Given this list of marker genes CAMKK2, MMP3, LBP, TMEM132C, PALLD, C1QA, GALNT14, ZEB1, TSN, PTGER3, NTNG1, LGMN, PDE4DIP, CTSB, FEM1B, CNTN1 (contactin 1), EGLN3, NRROS, TRIL, IL1R1, KIF26B, ZFP36L1, SLC7A10, NR0B1, RAB7B, RHBDL3, TSPAN2, CCDC80, ASNS, ARMCX2, WFIKKN2, HIVEP2, SLCO2B1, AR, TTYH3, CCKAR, ATP2B1, FOXO6, FILIP1L, XIST, RALGDS, WASF1, BMP2K (BMP2 inducible kinase), EYA2, PCDH18, TSPAN18, CD300C, PIP4K2B, CACNA2D3, FAM131A, PKNOX1, ARID5B, PDGFRB, SLC16A3, DACH2, ZNF521, KCNK9, MATN2, SH3PXD2B, RUNX1, RNF152, LYPD6B, SUFU, LRFN5, DUSP7, CD83, IGDCC4, FAM171B (family with sequence similarity 171 member B), KDM5C, PCDH19, RHOBTB2, NAPRT, BTD (NCBI Gene Id 92108), LHFPL3, ELN, IL17RD, DAB2IP, CHDH, SLITRK1, AKAP5, MACO1, CPXM2, SERPINF1, MFAP4, AMPH, RSPO2, ARMCX6, CDKL1, FNBP1L, C1QTNF7, GAD2, MBD1, MAB21L3, GPRASP1, CCDC74B, PPP1R3B, MEIS1, C15orf39, WNT7A, ABHD8, MMP16, CTTNBP2, PTCHD4, LONRF1, OXCT1, MEX3B, CDC42EP3, TSPYL5, DGKH, DAB2, GYPC, CD248, NETO1, STARD9, PI4KA, DDR2, ABI2, AHDC1, FAM107B, EPHB1, FBLN1, BMP3, SREBF1, ABLIM2, RYR3, CFAP418, INHBA (NCBI Gene Id 3624), PCDH10 (protocadherin 10), ANPEP, REC8, PRRX1, TGFBI, HIRIP3, SEMA5B, KRT75, PHACTR1 (phosphatase and actin regulator 1), CXCL13, MYB, CHRNA4, ELOVL6, PRKCB, CDH10, SOX17, NFIX (nuclear factor I X), PADI4, LARGE1, ERC1, THBS1, RYBP, SPATS2L, ELAC2, GABRB2, DNAI4, PBDC1, AVPR1A, RERG, SOCS1, MSRB2, LY6D, COMTD1, FOXP1, CD55, SKIDA1, CDIP1, NBEA, TGFB1I1, ISOC1, CRACD, SH3KBP1, ANGPTL6, C1QC, CNTNAP4, PABPC4L, DYNLT5, PTHLH, RAB3B, ARHGAP25, BCAT1, MAP4K5 (mitogen-activated protein kinase kinase kinase kinase 5), SAMD5, EPHA5, ONECUT2, PPM1A, ARL4C, LRFN2, RTN4R, KLF12, EPHA7, PRKD3, EDNRA, GFOD1, CABLES1, ZSWIM6, SHISA2, RIMKLA, RASSF2, ENPP1, LARP1, CENPE, RBBP9, COL8A1, CRABP1, NEDD9 (NCBI Gene Id 4739), ARHGAP42, EMILIN3, C9orf72, UBASH3B, MAMSTR, PREX1, GABRG3, LYSMD2, ADGRB2, IPO11, SMAD5, COLEC10, IRF1, G6PC2, SYNPO2, ST3GAL2, NUAK1 (NUAK family kinase 1, NCBI Gene Id 9891), FBXL7, SLC14A1, CHSY3, P4HA2, PROX1, ESR1, MMP10, GPM6B, HAVCR1, CDH6, DHRS7, ADAM23, NRP2, GREM1 (gremlin 1, DAN family BMP antagonist), SPON2, KRTDAP, PLXDC1, SLC1A4, AHR, SLC1A6, CBFA2T2, SLC1A1, WFDC2, CHST9, KNDC1, ADAMTS8, GRIN3A, IGFBP4, GABRB1, IRF2BPL, ST3GAL4, KIFAP3, ZNF704, SLC1A3, ZMAT4, CAMKV (NCBI Gene Id 79012), LHPP, PEX5L, DEF6, JUND, LMO3 (NCBI Gene Id 55885), PKD2, TCERG1L, GRIA1, RBMS3, TSIX, STXBP6 (syntaxin binding protein 6), TGFB3, DDX3X, PCDH20, NEGR1, EDIL3, PDE1A, TYROBP, KCTD1, PMEPA1, GAS1, AMHR2, RASSF4, SRGAP1, NTRK2, MIF, FGF18, FIBIN, EBF3, KCNAB1 (potassium voltage-gated channel subfamily A regulatory beta subunit 1), CACHD1, ABCC9 (ATP binding cassette subfamily C member 9), SH3BP5 (SH3 domain binding protein 5), CREB5, ENPP3, PARM1, RXFP1, GLIS2, TRPM5, ADAMTS19, LMNA, CYRIA, BLNK, PRTG, KDM6B, MYCN, PTEN, FAM181B, TENT5A, VSIR, MYH10, REV3L, MS4A7, MUC15, SPARCL1, SDC2, GABRA1, CACNA1G, PRR5L, GUCY1A1, KAZN, RHOJ, MFAP2, ENTPD4, LAPTM4B, ID4, SLIT2, DUSP2, TGFBR2, CCL11, DZANK1, ANTXR1, FAM8A1, SERTAD2, MED13L, ALDOC, SYT13, RBPJ, HS3ST4, LYZ, TIAM2, RSPO1, BCOR, DGAT2, PLA2G12A, CALN1, TRPC6, GUCY1B1, RUNX1T1, PER2, PKP4, ARMCX3, ADGRA1, AQP1, ADAMTS18, COPG1, LDB2, HSPA1A, PAPSS1, MCUR1, GABRA4, BACH2, KRT17, EIF2S3, S100G, PDE1B, MSX2, SLC26A7, SIPA1L2, ZNF536, CROCC, IGF1, CDCA7, SOX7 (NCBI Gene Id 83595), TMEM132E, STK3, RND3, ROBO2, KLF7, DUBR, PDLIM7, KCNA4 (NCBI Gene Id 3740), PACRG, BMF, QPCT, PNLIPRP1, CTPS2, SCX, SULF1, CSTA, FAM13A, MRGPRF, FOXJ3, DIXDC1, BST2, KLF10, SLC19A2, HDAC4, LOXL1, ITGA4, PAMR1, NR4A2, PAPPA, GAS2L3, DBX2, SNX20, NDRG1, DPP10, TCF4, ADGRL3, ANKRD6, TMEM213, DCC, here is a description of the gene set: Cancer cells differentiate along specific lineages that largely determine their clinical and biologic behavior. Distinct cancer phenotypes from different cells and organs likely result from unique gene expression repertoires established in the embryo and maintained after malignant transformation. We used comprehensive gene expression analysis to examine this concept in the prostate, an organ with a tractable developmental program and a high propensity for cancer. We focused on gene expression in the murine prostate rudiment at three time points during the first 48 h of exposure to androgen, which initiates proliferation and invasion of prostate epithelial buds into surrounding urogenital sinus mesenchyme. Here, we show that androgen exposure regulates genes previously implicated in prostate carcinogenesis comprising pathways for the phosphatase and tensin homolog (PTEN), fibroblast growth factor (FGF)/mitogen-activated protein kinase (MAPK), and Wnt signaling along with cellular programs regulating such 'hallmarks' of cancer as angiogenesis, apoptosis, migration and proliferation. We found statistically significant evidence for novel androgen-induced gene regulation events that establish and/or maintain prostate cell fate. These include modulation of gene expression through microRNAs, expression of specific transcription factors, and regulation of their predicted targets. By querying public gene expression databases from other tissues, we found that rather than generally characterizing androgen exposure or epithelial budding, the early prostate development program more closely resembles the program for human prostate cancer. Most importantly, early androgen-regulated genes and functional themes associated with prostate development were highly enriched in contrasts between increasingly lethal forms of prostate cancer, confirming a 'reactivation' of embryonic pathways for proliferation and invasion in prostate cancer progression. Among the genes with the most significant links to the development and cancer, we highlight coordinate induction of the transcription factor Sox9 and suppression of the proapoptotic phospholipid-binding protein Annexin A1 that link early prostate development to early prostate carcinogenesis. These results credential early prostate development as a reliable and valid model system for the investigation of genes and pathways that drive prostate cancer. Human Gene Set: SCHAEFFER_PROSTATE_DEVELOPMENT_48HR_DN Genes down-regulated in the urogenital sinus (UGS) of day E16 females exposed to the androgen dihydrotestosterone for 48 h. from publication Schaeffer EM, Marchionni L, Huang Z, Simons B, Blackman A, Yu W, Parmigiani G, Berman DM (PMID 18794802) species: Mus musculus